The following is a description of a gene set: Human Gene Set: GOBP_INTERFERON_MEDIATED_SIGNALING_PATHWAY species: Homo sapiens The series of molecular signals initiated by type II interferon binding to its receptor on the surface of a target cell, and ending with the regulation of a downstream cellular process, e.g. transcription. Type II interferon is also known as interferon-gamma., and this is the list of marker genes: METTL3, SMIM30, IFNL1, IFNA5 (NCBI Gene Id 89952), CNOT7, IRF7 (NCBI Gene Id 3665), TP53 (tumor protein p53), IFNA4, OASL, TRIM6, IFNL4, EPG5, SP100, IRF3, IL10RB, USP29, MAVS, IFNL3, ZBP1, PPARG, SAMHD1, IFNA1, IFNAR1 (interferon alpha and beta receptor subunit 1), PTPN2, IFITM1, MIR21, NLRC5, USP18, ADAR, USP27X, STAT1, MED1, TYK2, TBK1, HCK, CIITA, IFIH1 (NCBI Gene Id 64135), NR1H3, RAF1, IFNA14, IFNA10, OTOP1, STING1, UBE2K, RBM47, PARP14, CACTIN, ISG15, HDAC4, PTPN6, HPX, TANK, IFNE, IFNB1, IFI27, IFNGR1, YTHDF2, IFNGR2, GIGYF2, IFNG, IRF1, IFNL2, DNAJA3, OAS1, IFITM2, IFNA7, MUL1, AZI2, IFNA17, GPR108, IFNLR1, TRIM56 (NCBI Gene Id 81844), CDC37, PARP9, PTPN1, MMP12, TXK, IFNA8, IRAK1, JAK1, LSM14A, RNF185, MYD88, SIN3A, FADD (Fas associated via death domain), IRGM, IFNA2, IFITM3, EIF4E2, TBKBP1, IFNAR2, IFNK, CR2, IFNA16, IFNA6, WNT5A, TRIM65, PTPN11, IFNW1, NR1H2, DCST1, OAS3, STAT2, TTLL12, IFNA21, JAK2, IKBKE, YTHDF3, TRIM41, ARG1, TRAF3, OAS2, TREX1